Given this list of marker genes Hoxc13, Gabra1, Tcf7, Mfap1b, Mfap1a, Myo6, Grm4, Tmem134, here is a description of the gene set: Genes predicted to be targets of miRBase v22 microRNA mmu_miR_678 in miRDB v6.0 with MirTarget v4 prediction scores > 80 (high confidence targets). Mouse Gene Set: MIR_678 from publication Chen Y, Wang X (PMID 31504780) studied in species Mus musculus